Given this list of marker genes SNAP25, ZNF570, FAM89B, ZNF569, ZNRD2, ZBTB8A, JUN, KLK9, CCDC140, KCNK9, TCF7L2, COL2A1, ZNF532, HSD11B1, IL6R, LMO3, here is a description of the gene set: Human Gene Set: ALX4_01 Genes having at least one occurrence of the motif CCTGAGAATAATC in the regions spanning 4 kb centered on their transcription starting sites. This matches the ALX4 transcription factor binding site V$ALX4_01 (v7.4 TRANSFAC). studied in species Homo sapiens